Given this list of marker genes AP1S3 (adaptor related protein complex 1 subunit sigma 3), AP1S1, PACS1, AP1S2, nef, AP1B1, B2M, AP1G1, HLA-A, AP1M1, AP1M2, here is a description of the gene set: Reactome Pathway: Nef mediated downregulation of MHC class I complex cell surface expression part of: Nef-mediates down modulation of cell surface receptors by recruiting them to clathrin adapters species: Homo sapiens Down-regulation of MHC class I involves Nef-mediated connection in the endosomes between MHC-I's cytoplasmic tail and the phosphofurin acidic cluster sorting protein-1 (PACS-1)-dependent protein-sorting pathway. Down-regulation of MHC I protects HIV-infected cells from host CTL response.